The following is a description of a gene set: species: Homo sapiens Neonatal respiratory distress Human Gene Set: HP_NEONATAL_RESPIRATORY_DISTRESS Respiratory difficulty as newborn., and this is the list of marker genes: DNM1L, ENPP1 (NCBI Gene Id 5167), ZC4H2, DNAH1, COLQ, PEX1, MADD, SNRPB, HACD1, PIK3CD, NR1H4 (NCBI Gene Id 9971), KNSTRN (NCBI Gene Id 90417), ODAD3 (outer dynein arm docking complex subunit 3), ODAD1, ASXL1, PTCD3, TOR1A, MDFIC, DRC1, DNAAF2, DNAH11 (NCBI Gene Id 8719), RSPH1, SRP54, PLCB3, PDHA1, DDX3X, GLUL, DMPK, DNAAF6, ALDH1A2, GMPPA, CPT2 (carnitine palmitoyltransferase 2), ODAD2, TRAF7, CCDC65, MYH3, ATP8B1, GALK1, LONP1, PAX2, BIN1, ALG14, LRRC56, COX6A2, SPOP, GLYCTK, DNAL1, GAS2L2, FBN1, PLCB4, CCNO, RSPH3, NDUFB10, ABCB11, COG7, MCIDAS, GPC4, SFTPB, CFAP74, DNAJC21, RSPH9, KIAA0753, NPHS1, MT-TT, ODAD4, DNAAF5, DNAH9, NME5, HSD3B2, DNM2, SBDS, SNAP25, SUCLG1, FOXF1, RSPH4A, NFASC, ITGA3, SPAG1, RUNX2, KAT6A, COX14, KIF22, RAPSN, DNAAF1, FOXJ1, MYF6, NME8, DNAAF11, GNB2, RYR1, MED12, HYDIN, XYLT1, GSC, CFAP300, PLEC, CCDC40, SHPK, DNAJB13, WT1, SLC30A9, SMPD4, DNAH5, DNAI1, DPM2, NKX2-1, NSF, CCDC39, TRIP4, SPEF2, RNF168 (NCBI Gene Id 165918), DNAAF3, NUP214, HYMAI, SLC27A4, MTMR14, CFAP298, PLPBP, FGFR3, MLYCD, CFAP221, SCN4A, CANT1 (calcium activated nucleotidase 1), DNAAF4, SOX9, AEBP1, RPGR, ASCC1, RALGAPA1, PLAGL1, DNAI2, ARSL (NCBI Gene Id 415), GPC3, DST (dystonin), NPC2, ZMYND10, CSGALNACT1, LAMB2, ABCA3, NEK10, CUL7, UBE3B, NALCN, AHDC1, CHRNG, OFD1, STK36, PBX1, TTC12, ALDH7A1, GRM7, MTM1, ABCB4